The following is a description of a gene set: species: Mus musculus Genes up-regulated in placenta of mice with EHMT2 knocked out. from publication Wagschal A, Sutherland HG, Woodfine K, Henckel A, Chebli K, Schulz R, Oakey RJ, Bickmore WA, Feil R (PMID 18039842) Mouse Gene Set: WAGSCHAL_EHMT2_TARGETS_UP Whereas DNA methylation is essential for genomic imprinting, the importance of histone methylation in the allelic expression of imprinted genes is unclear. Imprinting control regions (ICRs), however, are marked by histone H3-K9 methylation on their DNA-methylated allele. In the placenta, the paternal silencing along the Kcnq1 domain on distal chromosome 7 also correlates with the presence of H3-K9 methylation, but imprinted repression at these genes is maintained independently of DNA methylation. To explore which histone methyltransferase (HMT) could mediate the allelic H3-K9 methylation on distal chromosome 7, and at ICRs, we generated mouse conceptuses deficient for the SET domain protein G9a. We found that in the embryo and placenta, the differential DNA methylation at ICRs and imprinted genes is maintained in the absence of G9a. Accordingly, in embryos, imprinted gene expression was unchanged at the domains analyzed, in spite of a global loss of H3-K9 dimethylation (H3K9me2). In contrast, the placenta-specific imprinting of genes on distal chromosome 7 is impaired in the absence of G9a, and this correlates with reduced levels of H3K9me2 and H3K9me3. These findings provide the first evidence for the involvement of an HMT and suggest that histone methylation contributes to imprinted gene repression in the trophoblast., and this is the list of marker genes: Magea6, Nppb, Pfpl, Prl5a1, Naa11, Asz1, Magea14, Cftr, Tfpi2, Cmtm5, Tktl2, Pdha2, Cts7, 1700013H16Rik, Klk12, Dazl, Nxf3, Gtsf1, Timm8a2, Cdkn1a